Given this list of marker genes DAP, CYTIP, TGIF1, TMPRSS11E, JAK2, PTPN22, KDM2B, ANXA1, CDYL2, SLC17A6, MLLT3, TNFSF14, ZAP70, THEMIS, EVI2B, SLC25A24, EEA1, BTLA, IL2, POU2AF1, ZFP36L1, CRTAM, TNFRSF19, ITK, PTGER4, LPXN, GPR171, PHF6, ADAM10, MBP, here is a description of the gene set: Genes with promoters bound by FOXP3, dependent on it, and up-regulated in hybridoma cells stimulated by PMA and ionomycin. from publication Marson A, Kretschmer K, Frampton GM, Jacobsen ES, Polansky JK, MacIsaac KD, Levine SS, Fraenkel E, von Boehmer H, Young RA (PMID 17237765) Foxp3+CD4+CD25+ regulatory T (T(reg)) cells are essential for the prevention of autoimmunity. T(reg) cells have an attenuated cytokine response to T-cell receptor stimulation, and can suppress the proliferation and effector function of neighbouring T cells. The forkhead transcription factor Foxp3 (forkhead box P3) is selectively expressed in T(reg) cells, is required for T(reg) development and function, and is sufficient to induce a T(reg) phenotype in conventional CD4+CD25- T cells. Mutations in Foxp3 cause severe, multi-organ autoimmunity in both human and mouse. FOXP3 can cooperate in a DNA-binding complex with NFAT (nuclear factor of activated T cells) to regulate the transcription of several known target genes. However, the global set of genes regulated directly by Foxp3 is not known and consequently, how this transcription factor controls the gene expression programme for T(reg) function is not understood. Here we identify Foxp3 target genes and report that many of these are key modulators of T-cell activation and function. Remarkably, the predominant, although not exclusive, effect of Foxp3 occupancy is to suppress the activation of target genes on T-cell stimulation. Foxp3 suppression of its targets appears to be crucial for the normal function of T(reg) cells, because overactive variants of some target genes are known to be associated with autoimmune disease. studied in species Mus musculus Human Gene Set: MARSON_FOXP3_TARGETS_STIMULATED_UP